The following is a description of a gene set: This COVID-19 pathway has been created by a combination of computational inference from SARS-CoV-1 data (https://reactome.org/documentation/inferred-events) and manual curation, as described in the summation for the overall SARS-CoV-2 infection pathway.<br><br>In a sequence of ten reactions, mature non-structural proteins (nsp) generated by cleavage of the SARS-CoV-1 pp1a / pp1ab polyproteins are assembled to form the RTC (Fung & Liu 2019; Kirchdoerfer & Ward 2019). Six of these ten steps have been directly studied in SARS-CoV-2: binding of nsp7 to nsp8, recruitment of nsp12, binding of nsp14 and nsp10, binding of nsp13 to nsp12 formation of the nsp15 hexamer, and binding of nsp16 to nsp12. Reactome Pathway: Assembly of the SARS-CoV-2 Replication-Transcription Complex (RTC) species: Homo sapiens part of: Translation of Replicase and Assembly of the Replication Transcription Complex, and this is the list of marker genes: pp1a, rep